Given this list of marker genes Unc93b1, H2-Aa, H2-DMb1, H2-Ob (histocompatibility 2, O region beta locus), H2-DMb2, Trem2 (triggering receptor expressed on myeloid cells 2), Fcgr2b, Cd74, Marchf8, H2-Eb1, Ctss, Pycard, H2-Eb2, H2-Ea, Thbs1, H2-Oa, H2-DMa, Ifi30, Arl8b, Pikfyve, Marchf1, B2m, Ctse, Fcer1g, Lgmn, Traf6, H2-Ab1, here is a description of the gene set: Mouse Gene Set: GOBP_ANTIGEN_PROCESSING_AND_PRESENTATION_OF_PEPTIDE_OR_POLYSACCHARIDE_ANTIGEN_VIA_MHC_CLASS_II The process in which an antigen-presenting cell expresses antigen (peptide or polysaccharide) on its cell surface in association with an MHC class II protein complex. studied in species Mus musculus